The following is a description of a gene set: species: Homo sapiens Pathway Definition from KEGG: MET* -> GAB1 -> PI3K -> PIP3 -> AKT -> MTOR Amplified MET to PI3K signaling pathway. Pathway ID: N00260. Pathway type: Variant. Pathway class: nt06261 Gastric cancer. Human Gene Set: KEGG_MEDICUS_VARIANT_AMPLIFIED_MET_TO_PI3K_SIGNALING_PATHWAY, and this is the list of marker genes: AKT1, AKT2, MET, AKT3, GAB1, PIK3CB, PIK3CD, PIK3CA, MTOR